Given this list of marker genes DEPP1, SLC26A7, FGFR1 (NCBI Gene Id 84151), MLN, GHRL (ghrelin and obestatin prepropeptide), ARX, ACSL1, PCLO, VAMP2, KCTD12, SCGN, PCSK1N, CPE, here is a description of the gene set: studied in species Homo sapiens from publication Busslinger GA, Weusten BLA, Bogte A, Begthel H, Brosens LAA, Clevers H (PMID 33691112) Human Gene Set: BUSSLINGER_DUODENAL_MX_CELLS